The following is a description of a gene set: Human Gene Set: GOBP_NEURAL_CREST_CELL_MIGRATION_INVOLVED_IN_AUTONOMIC_NERVOUS_SYSTEM_DEVELOPMENT species: Homo sapiens Any neural crest cell migration that is involved in autonomic nervous system development., and this is the list of marker genes: SEMA3A, NRP1, FN1, NRP2, SEMA3F, PHOX2B